Given this list of marker genes CDH5, IFI16, DDX39A, C5AR2, NPY, FPR2, VPS35, UBASH3B, CYLD, ALOX12, TAFA5, STAT2, MACIR, PSMB4, PARP14, TNFAIP8L2, IGF1, KREMEN1, AURKB, GRID2 (NCBI Gene Id 2895), SYT11, NT5C2, ILRUN, TTLL12, MIR16-1, RABGEF1 (NCBI Gene Id 27342), BCR, GSTP1, DRD1, CST7, KLRC4-KLRK1 (NCBI Gene Id 100528032), SLIT2, EIF4E2, GPER1, GRB2, MIR181A2, DNAJA3, ROBO2, ASH1L, TRIB1, SIRPA, ROBO1, MMRN1, PTPRS, DRD3, SLAMF8, PDGFA, NR1D2, IL12B, PCBP2, SIGIRR, GIGYF2, SPN, MIR4286 (microRNA 4286), PROS1, MIR181C, OTOP1, RTN4R, RNF26 (ring finger protein 26), MIR138-1, KRT1, WNT3, MMP12, SERPINB4, PDGFRA, USP15, PIM1, DPP4, CARD16, HGF, MIR3909, NLRP3, FOXF1, FFAR4, GNAS, RORA, CRK, PGLYRP1, SAA1, TGFB1, TRIM65, FGG, FGR, SLC39A8 (NCBI Gene Id 64116), LRIG2, CD96, GRIN3A, SEMA5A, SLC12A2, KLRD1, MIRLET7G (NCBI Gene Id 406890), PF4, PADI2, TRIM38, PTPRC, MDK, TNFAIP6 (TNF alpha induced protein 6), ELF4, DCST1, LYN, CHD8, MIR424, MIR26A1, CLEC12A, CNOT7, FURIN, ITCH, INPP5D, SIGLEC10, RGMA, CYP19A1, IL13, PLCG1, INPP5F, FYN, USP38, MAPKBP1, HLA-E, TNFRSF1B, PLAU, MIR766, FXR1, MIR6869, YTHDF2, KLKB1, LILRA2, F12, CCN3, MIR145, MIR181B1, OAS3, FAM3A, MMP28, AIF1, C5, HDAC6, PSMA1, CD109, NOTCH1, NDFIP1, SH2B3, SLC6A3, STAP1, TEK, MIR1298, SERPINF2, CEACAM1, DUSP1, PLA2G10, DTX4, SERPINB9, TNF, LACRT, GP1BA, PTGER4, ADAMTS18, MIR19B1, APOH, CACTIN, GPR17, ZDHHC18, TAFA3, NR1D1, HLA-G, NLRP4, MIR21, ARG2, TRIM45, TNFRSF1A, MIR488, PRDX2, ADORA1, LDLR, MUL1, FGA, MIR199A1, DDT, TMX1, APOA1, NFKBIL1, THBD, CR1, CNTNAP2, PRKG1, PLK2, PTGIS, THBS1, TRAFD1, MIR187, ELANE, EDN1, ANGPT2, MIR20A, NR5A2, SMAD3, ADTRP, CXCL13, FGF2, BANF1, MIR19A, ACP5, C1QBP, KIR2DL4, MIR30C2, EPHA4, TRIM21, RPS19, MKRN2 (NCBI Gene Id 29073), PYDC2, APOE, FIGNL2, TNR, IL4, HCK, CCL2 (NCBI Gene Id 6347), ADAR (NCBI Gene Id 3427), IL17A, SOCS5, LILRB1, CARD8, ARG1, IL2RA, DHX58, VSIG4, PRKCD, STAT3, MICB, IL33, FCGR2B, CASK (NCBI Gene Id 8573), YES1 (NCBI Gene Id 7525), CLASP2, CD9, SMPDL3B, MIR142, CXCL17, LYAR, PTPRO, UACA, TYRO3, PLG, A2M, PBK, GATA3 (NCBI Gene Id 84828), NMI, NR1H3, IL22RA1, MICOS10-NBL1, PDGFB, IRAK3, PLXNA3, NPY5R, WNT5A, IL2, SERPINB2, WNT3A, CLASP1, SEMA3F, DUSP3, TARBP2, MYOZ1, MIR34A, NEO1, ADIPOQ, HAVCR2, F2, ARNT, MIR302E, NT5E, SOD1, IER3, MIR92A1, LGALS9, IL22, MAPK7, CD200, KLF4, YWHAZ, GPR18, NLRP6, NBL1, FAP, INS, WFDC1, FAM76B, METTL3, NLRP12, MIR590, GIT1, IL20RB, ADORA2A, USF1, MIR141, APCS, NECTIN2, MIR149, CERS2, KLRK1, FGL2 (NCBI Gene Id 10875), PPARA (NCBI Gene Id 84730), RTCA, GPR31, EXTL3, PTEN, WNT4, ANXA2 (NCBI Gene Id 792), CD200R1, DRD2, KIAA0319, SERPINE2, TRAF3IP1, SBNO1, MMP26, IL10, VTN, SPP1, MIR920, CEP63, MIR200B, SERPING1, GBA1, SELENOS, SFN, RTN4RL1, PLAT, ATG5, EPPK1 (epiplakin 1), SAMHD1, FEM1A, PPARD, MIR195, MIR4691, TMSB4X, AOAH, DVL1, MIR105-1, PTPN6 (NCBI Gene Id 5777), SLIT1, DEFB114, MIR222, LPCAT3, LRFN5, ISL1, AJAP1, MIR15B, METRNL, TREX1, SYK, IL10RA, MAPK14, ACOD1 (aconitate decarboxylase 1), C1QTNF12, RYK, SOCS3, PPM1B, SERPINE1, NLRC5, CPB2, MFHAS1, MIR26B, SHARPIN, RHBDF2, PROC, ISG15, HRG, OAS1, GPS2, MVK, ADA (NCBI Gene Id 100), MIR204, NFKB1, CTNNA2, PTPN2, NLRX1, TREM2, PLAUR, OTULIN, TSPAN8, SRC, YTHDF3, NOS3, CLEC12B, MIF, DUSP10, AHR, NR1H4, DSG2, NR1H2, SMIM30, KLRC1, FGB, NECTIN4, GRN, USP18, HLA-DRB1, GHRL, C1QTNF1, MEFV, NLRC3, DEFB118, TIGIT, TFPI, PVR, GHSR, CX3CL1, FNDC4, GREM1, MIR15A, KNG1, MIR205 (microRNA 205), RB1, ENPP3, F11, ARRB2, SUSD4, IRGM, NRP1, PARP1, MIR221, MICA, CORO1B, MIR146A, MIR31, FOXP3, RIN3, C1QTNF3 (NCBI Gene Id 81699), IL22RA2, HLA-F, ATG12, LTF, GPX1 (glutathione peroxidase 1), PPARG, BACE1, SPINK5, TNFAIP3, REG3A, PHLDB2, HLA-B, ALOX5, PPP1R13L, MIR223, HLA-A, here is a description of the gene set: Any process that stops, prevents, or reduces the frequency, rate or extent of a response to an external stimulus. Human Gene Set: GOBP_NEGATIVE_REGULATION_OF_RESPONSE_TO_EXTERNAL_STIMULUS studied in species Homo sapiens